The following is a description of a gene set: species: Homo sapiens Human Gene Set: HE_LIM_SUN_FETAL_LUNG_C0_VASCULAR_SMC_2_CELL Vascular SMC 2 from publication He P, Lim K, Sun D, Pett JP, Jeng Q, Polanski K, Dong Z, Bolt L, Richardson L, Mamanova L, Dabrowska M, Wilbrey-Clark A, Madissoon E, Tuong ZK, Dann E, Suo C, Goh I, Yoshida M, Nikolić MZ, Janes SM, He X, Barker RA, Teichmann SA, Marioni JC, Meyer KB, Rawlins EL (PMID 36493756), and this is the list of marker genes: INHBA, WFDC1, KCNS3, MARK1, NRGN, BCAR3, TESC, FOXS1, NOTCH3, TNNT2, LDB3, TMEM51, NET1, GATM, GRP, ATP1A2, MED14, BTC, CASQ2, MYH11, ANOS1, PHLDB2, CTNNA3, FGF13, DBNDD2, MYOZ1, HIGD1B, PDGFA, CRIP1, KCNC4, DGKH, MOCS1, COL8A1, PGM5P3-AS1, HEYL, CDH13, HRC, GJA4, CAV2, VAT1L, SEPTIN5, ESAM, RASL11A, TTYH1, ARHGEF7, RIPOR2 (RHO family interacting cell polarization regulator 2), LRRC32, PLCE1, HSPB7, KCNA5, GPRC5C, PDE3A, MEF2C, HIP1, LMOD1, PGM5P4-AS1 (NCBI Gene Id 124906859), MTHFD2, RERG, OLFML2A (olfactomedin like 2A), RRAD, ABR, DGKZ, HOXB-AS1, AFAP1L2, MAMDC2, PLXDC1, ITGA4, CSRP2, TLCD5, LASP1NB, SEMA5B, ENTPD1, MYOCD, EXD3, NRIP2, SYNGR2, MYOM2, IL17RE, EFNB2, ITGA7, EPAS1, RCSD1, IGFBP2, SIPA1L2, INPP4B, CHST7, ADGRE5, LIX1, THSD4, ARID5A, TRPC6, JAG1 (jagged canonical Notch ligand 1), LGALSL, ACAN, PPFIBP2, PLP2, PERP, HS3ST1, TP53I11, ALCAM, PLN, DMPK, RASD1, ARHGAP29, MCAM, CAP2 (NCBI Gene Id 10486), SUSD5, RAPGEF5, ALDOC, ZNF385B, HSPA2, RCAN2, SEPTIN4, CTXN1, RGS16, ARHGDIB, PI15, MAP3K7CL, TM4SF1, ALDH1A2 (NCBI Gene Id 8854), FRY, FILIP1L, NTRK3, TSPAN2 (tetraspanin 2), C1QTNF1, NDUFA4L2, PARM1, OLFML2B, MSRB3, ACTG2, NAB1, HACD1, EBF1, PEG3, COX4I2, NIBAN1, RASGRP2, HMCN1, HES4, RGS5 (regulator of G protein signaling 5), CSPG4, ZHX2, PLEKHG3, TBC1D1, IL17B, LIMS2, KLHL23, ADIRF, FRZB, HEY2, SPTB, TINAGL1, B3GNT2, SLC8A1, BCAS3, NTN4, HRH2, NOL3, SGCA, FRK, PDLIM5, NTF3, MEGF6, CNNM2, SERPINI1, CDH6, WWP2, AIF1L, FJX1, COL18A1, FAM241A